The following is a description of a gene set: species: Mus musculus Mouse Gene Set: GOBP_DETOXIFICATION_OF_NITROGEN_COMPOUND Any process that reduces or removes the toxicity of nitrogenous compounds which are dangerous or toxic. This includes the aerobic conversion of toxic compounds to harmless substances., and this is the list of marker genes: Gstm6, Gstm3, Gstm5, Mtarc2, Gstm7, Mtarc1